Given this list of marker genes Msh2, Tgfb1, Pms2, Mlh1, Nsd2, Tnfsf13, here is a description of the gene set: Any process that activates or increases the frequency, rate or extent of isotype switching to IgA isotypes. species: Mus musculus Mouse Gene Set: GOBP_POSITIVE_REGULATION_OF_ISOTYPE_SWITCHING_TO_IGA_ISOTYPES